The following is a description of a gene set: An elevated level of a proteinogenic amino acid in the blood circulation. These are the 23 alpha-amino acids that are precursors to proteins, and are incorporated into proteins during translation. The group includes the 20 amino acids encoded by the nuclear genes of eukaryotes together with selenocysteine, pyrrolysine, and N-formylmethionine. Human Gene Set: HP_ABNORMAL_CIRCULATING_PROTEINOGENIC_AMINO_ACID_CONCENTRATION studied in species Homo sapiens Abnormal circulating proteinogenic amino acid concentration, and this is the list of marker genes: HPD, SKIC3, COX16, MMADHC, SLC30A10, TFAM (NCBI Gene Id 8033), MCCC2, GCSH, TAT, COX10, SARDH, GLYCTK, SLC6A18, ASNS, SLC7A7, PPM1K, ADK, ALDH4A1 (aldehyde dehydrogenase 4 family member A1), FAH, PCCA, MTRR, DLD, AASS, PDP1, TEFM, BCKDK (NCBI Gene Id 94996), PAH, GUCY2D, GPHN, TARS2, PET117, ATP5F1B, MTR, TNFRSF11B, BOLA3, PSAT1, NADK2, PTS, PSPH, ASL, OTC, CPS1 (NCBI Gene Id 1373), MMAA, MAT1A, IRF6, NFS1, MMACHC, MMAB, GLDC, COX8A, KYNU, PRDX1, GLS, SLC36A2, NDUFC2, GLUL, NFU1, SLC19A1, SPR, NR4A2, MICU1 (mitochondrial calcium uptake 1), UROC1, CBS (cystathionine beta-synthase), ATP5F1A, GCH1, ARG1, MTHFR, HAL, SLC6A20, BCKDHB, HCFC1, TALDO1, PNPO, IBA57, PCBD1, LIPT2, NDUFB10, ABCD4, ALDH18A1 (aldehyde dehydrogenase 18 family member A1), PHGDH, QDPR, BCKDHA, MTHFD1, CA5A, NFE2L2, MCEE, SLC25A13, BCAT2 (NCBI Gene Id 587), SLC6A19, GLRX5, MMUT, CD320, IMPDH2, PRODH, TDO2, MDH1, AMT, PCCB, LIPT1, FTCD (formimidoyltransferase cyclodeaminase), MPV17 (mitochondrial inner membrane protein MPV17), COX5A, TCN2, GNMT, MCCC1, LMBRD1, AHCY, BCS1L, SUCLG1, ASS1, NAGS